Given this list of marker genes Psma5, Pola2, Lin37, Cdkn1b (NCBI Gene Id 12576), Cul1, Psmc2, Rbbp4, Rbl2, Psma4, Psmc4, Ccna1, Mcm8, Ccne1, Cdkn1a, Cdkn1c, Pola1, Orc3, Ccne2, Mcm7, Psma1, Prim1, Mcm2, Mcm4, Psmd13, Orc5, Psma6, Cdk4, Ppp2r1b, Psmd12, Cdc7, Cdkn2b, Psmc1, Orc1 (origin recognition complex, subunit 1), Psmd6, Cdc45, Cdc6, Dbf4, Tfdp1, Psmd1, Rb1, Psmb6, Ubb, Gmnn, Psma3, Psma2, Psmb5, Pole2 (polymerase (DNA directed), epsilon 2 (p59 subunit)), Rps27a, Rpa1, Wee1, Pole, Orc4, Lin52, Psmd7, E2f3, Cables1, Psmc6, Psmb4, Lin54, Ccnd1, Ccnh, Psmc5, Psma7, E2f1, Psmb7, Ppp2r2a, Psmc3, here is a description of the gene set: electronically inferred by orthology from the curated human pathway part of: Cell Cycle, Mitotic species: Mus musculus Reactome Pathway: Mitotic G1 phase and G1/S transition This event has been computationally inferred from an event that has been demonstrated in another species.<p>The inference is based on the homology mapping from PANTHER. Briefly, reactions for which all involved PhysicalEntities (in input, output and catalyst) have a mapped orthologue/paralogue (for complexes at least 75% of components must have a mapping) are inferred to the other species.